Given this list of marker genes MT-ATP6, MAPT, GRHL2, KCNA1 (NCBI Gene Id 729214), SCN4A, HLA-A, NLRP3, COL4A1, CACNA1A, SCN9A, NDUFS2, COL17A1, CLCNKB, OVOL2 (ovo like zinc finger 2), MT-ND2, VSX1, MT-CO1, PTPN22, TGFBI, TRANK1, SLC12A3, ABCA1, TACSTD2, COL8A2, LCA5, NOP56, APOA1, DBH, MT-ND1 (NCBI Gene Id 4535), HLA-DRB1 (major histocompatibility complex, class II, DR beta 1), ZEB1, LRAT, SOST, SLC4A11, MT-ND6, ATP1A2, FAS, SPATA7, MT-ND5, MT-CO3, MT-ND4L, MT-ND4, DNAJC30, RPE65, HGSNAT, MT-CYB, here is a description of the gene set: Human Gene Set: HP_BLURRED_VISION Lack of sharpness of vision resulting in the inability to see fine detail. Blurred vision studied in species Homo sapiens